Given this list of marker genes HLA-G, HLA-B, CTSS, HLA-F, HLA-A, CTSV (cathepsin V), HLA-C, B2M, CTSL, LNPEP, HLA-E, here is a description of the gene set: Human Gene Set: REACTOME_ENDOSOMAL_VACUOLAR_PATHWAY Endosomal/Vacuolar pathway species: Homo sapiens